Given this list of marker genes H2BC10, CSNK2A2, PPP2R5C, PSMA2, CAV1, SFRP1, DVL2, H3C12, SOX4, KREMEN1, FRAT1, PYGO1, H4C4, WNT8A, PSMD3 (NCBI Gene Id 94019), CUL3, H4C5, H3C14, CDC73, H3C4, H4C13, CHD8, H2BC13, H2BC6, TLE1, CXXC4, SRY, H4C1, H4C8, GSK3B, H4C6 (H4 clustered histone 6), LEO1, LRP5 (LDL receptor related protein 5), PPP2CB, TCF7L2, H2BC11, PSMA1, H2BC1, H2AC6, PPP2R1A, AXIN2, PSMD6, LEF1, WNT1, CSNK1G2, KLHL12, H3C3, H2BC14, FZD6, PSMD8, TLE2, RNF146 (NCBI Gene Id 81847), PSMD7, WIF1, H2BC17, ADRM1, SMARCA4, SOX7, SOX2, H2AB1, PPP2R5D, PIP5K1B, RNF43, H2BC5, FZD5, HECW1, PSMA7, UBA52, H3C6, H3C1, PSMD12, ASH2L, XIAP, SOX17, H4C14, LRP6, RBBP5, MYC, WNT9A, BCL9, H4C9, WNT3A, H2BC7, AKT2, RSPO2, CSNK1A1, H2BC26, FZD4, H3C2, CTBP1, H4C11, CREBBP, CSNK1E, AXIN1 (axin 1), H2BC9, H2AC14, RYK, YWHAZ, TCF7L1, DKK4, H2AC7, WNT5A, H2BC21, SOX6 (SRY-box transcription factor 6), H3-3B, PSMB7, PPP2R5E, AMER1, TLE4, PSMD11, PSMA3, H2BC8, DKK1, RSPO3, H2AZ2, UBB, CSNK2B, FZD1, H2AC20, LGR6, SFRP2 (secreted frizzled related protein 2), SEM1, PSMB4, TERT, KREMEN2, SOX9, MEN1, H3-3A (H3.3 histone A), APC, WNT4, PSMC2, XPO1, RSPO1, BTRC, H4C2, PSMA5, H4C15, PSMC4, DVL1, USP8, SMURF2, H4C16, CTNNBIP1, PSMB6, H3C13, PYGO2, DKK2, PSMC5, WNT3, TNKS2, CBY1, H3-4, H4C12, PSMD13, BCL9L, H2AC19, PSMB2, CTNNB1, ZNRF3, PSMB3, UBC, TLE3, H2AC18, H3C15, PSMB5, SOX3, RUNX3, PSMD14, RUVBL1, SOX13, FZD8, SOST, H3C7, WNT8B, PPP2R1B, AKT1, TRRAP, H3C8, TCF7, H2BC15, H2AC8, CCDC88C, H3C11, LGR5, PSMA6, CSNK2A1, FRAT2, PPP2R5B, RSPO4, EP300, PSMB1, RPS27A, HDAC1, DACT1, TCF4, H2BC12L, KAT5, PSMC1, H2BC3, PSMD1, H2BC12, KMT2D, LGR4, PSMD2, PSMC6 (NCBI Gene Id 63380), PSMC3, H2AJ, DVL3, H2AX, RBX1, H2AC4, PSMA4, TNKS, USP34, PPP2CA, H3C10, H2BC4 (NCBI Gene Id 8347), PPP2R5A, H4C3, FZD2, here is a description of the gene set: Human Gene Set: REACTOME_TCF_DEPENDENT_SIGNALING_IN_RESPONSE_TO_WNT TCF dependent signaling in response to WNT studied in species Homo sapiens